The following is a description of a gene set: Human Gene Set: GOBP_NEGATIVE_REGULATION_OF_ACTION_POTENTIAL Any process that stops, prevents, or reduces the frequency, rate or extent of action potential creation, propagation or termination. This typically occurs via modulation of the activity or expression of voltage-gated ion channels. species: Homo sapiens, and this is the list of marker genes: BIN1, CHRNB2, HCN1, SUMO1, CNR2 (cannabinoid receptor 2)